Given this list of marker genes TRUB2, SGF29, ZNF41, INIP (NCBI Gene Id 58493), PAFAH1B2, MAP1LC3C, VDAC1, OBP2A, H2BC7, CCT5, FECH, DIMT1, LSM6, SOX15, MTR, ABHD5, HSP90AB1, PLAA, SNX14, THRAP3, AAAS, RBM19, ITGA11 (integrin subunit alpha 11), SNX13, GPR107, UBE3C, NUS1P3, WDR77, LSM12, EDN3, POGLUT1, PRMT5, LINC00310, NAA15, TGDS, SHLD2, APIP, CHMP3, ANKHD1, SF3B3, TRIM61, POLR1D, NRDE2, CEP135, ASMTL-AS1, HDAC8, RAB11FIP2, RABL3, PSMA2, MRPL42, NKAPD1, KCNH8, MSL1, ANGPTL8, YAF2, MRPS27, PSMA5, SLC38A6, POP1, RPP40, BRD2, LY6G6C, SH3GLB2, PNP, BCLAF1, ZFP64, DKC1, OPA1, POMGNT1, PDE4DIP, MARS2, NBN, CASP3, PPP2R1B, LANCL2, DNAJA3, RUFY1, TRIP11, DGKH, ZNF579, RCSD1, SGO1, PDZD8, PFDN4, CRLS1, NDUFAF5, NPRL3, MRPL21, RNPC3, SNHG29, ENOPH1, PAK1, ENOX1, TRAM1, CSTF1, USP39, IPPK, ATXN10, CDK3, H1-10, LINC00299, DDX31, SMG8, DOT1L, NUBP1, PLA2G7, DNAJC10, KAT2A, GDAP1, ACTG1P25, FAM83B, SFXN4, TYW3, METTL21A, H1-2, TACC1, DDX28, TEX2, EIF2B2, WSB2, RRP1B, PRM3, CCP110, DNAAF5, HPDL, BPNT1, RPL22L1, NUP50, SLC25A33, TRIM37, SAAL1, POLR3B, TUBGCP4 (NCBI Gene Id 27229), NUP188, H2BC12, SNX10 (sorting nexin 10), ITGAM, TYSND1, CANX, H2BC12L, TGFBRAP1 (NCBI Gene Id 9392), LYRM4 (NCBI Gene Id 57128), SPRR1A, TAPT1, ERICH1, THOC5, OSTC, ATAD3B, ZFP36, LIG3, MRPS35, PPP6R3, GTF2A1, SLC5A6, METAP1, TMEM204 (transmembrane protein 204), CZIB, CPSF6, SLC43A2, TMEM126B, DUSP23, DHX35 (NCBI Gene Id 60625), TOMM40L, SLC25A32, COMMD9, PNPT1, RAB28, SSR3, PPP2CA, NAT10, KLK5, MYL9, RSAD1, ASF1A (anti-silencing function 1A histone chaperone), DCAF7, DCAF1, PDHX, CPA1, PIN1P1, TRIM27, CA5A, MEGF6, BNIP1, TXNDC12, TPGS1, EIF5A2 (eukaryotic translation initiation factor 5A2), GHITM (growth hormone inducible transmembrane protein), BPNT2 (3'(2'), 5'-bisphosphate nucleotidase 2), THNSL1, PEX26, PSMD10, PDIA5, ILF3, PNPO, C1QBP, CPSF2, ZNF81, C11orf21, here is a description of the gene set: Human Gene Set: GSE2770_UNTREATED_VS_ACT_CD4_TCELL_48H_UP Genes up-regulated in CD4 T cells: untreated (0h) versus activated by anti-CD3 and anti-CD28 (48h). studied in species Homo sapiens Th1 and Th2 cells arise from a common precursor cell in response to triggering through the TCR and cytokine receptors for IL-12 or IL-4. This leads to activation of complex signaling pathways, which are not known in detail. Disturbances in the balance between type 1 and type 2 responses can lead to certain immune-mediated diseases. Thus, it is important to understand how Th1 and Th2 cells are generated. To clarify the mechanisms as to how IL-12 and IL-4 induce Th1 and Th2 differentiation and how TGF-beta can inhibit this process, we have used oligonucleotide arrays to examine the early polarization of Th1 and Th2 cells in the presence and absence of TGF-beta after 0, 2, 6 and 48 hours of polarization. from publication Lund R, Aittokallio T, Nevalainen O, Lahesmaa R (PMID 14607935)